The following is a description of a gene set: species: Homo sapiens Hypertrichosis is increased hair growth that is abnormal in quantity or location. Hypertrichosis Human Gene Set: HP_HYPERTRICHOSIS, and this is the list of marker genes: PPARG, KIFBP, GABRA3 (NCBI Gene Id 2556), SMARCC2, PCDHGC4, PIGN, KIAA0753, TAF6, CDKN2A, UROS, CHMP1A, PRR12, PACS1, FLII, NDST1 (NCBI Gene Id 3340), TRMT1 (tRNA methyltransferase 1), PGM2L1, GJA8, ARID1A, UQCC2, SNAI2 (NCBI Gene Id 6591), PLCB4, SMARCE1, SOX5, BLM, CASP2, TRMT10A, SMC1A, AFF4, DYM, FHL1, ZNF711, ZFX, HEATR3, TRAIP, PIK3CD, NAGLU, PTCH1, ADAMTS3, SMARCB1, FOS, KRT10, TMEM147, CCDC47, MASP1, TERT, ARID1B, SOX4, CDC42BPB, SCN4A, RAB34 (NCBI Gene Id 83871), COG7, CHRNA7, MITF, SLC4A10, NUDT2, COX5A, EHMT1, KIT, PUF60 (poly(U) binding splicing factor 60), MT-TQ, HNRNPU, MT-ND4, DPF2, ABCC9, PACS2, SMS, RNF125, BICRA, SMCHD1, CTSC, WAC, TALDO1, SMARCA4, ALK (NCBI Gene Id 238), HGSNAT, ZNF407, ATP6V1B2, MAPK8IP3, FBXO31, NANS, HECTD4, WARS1, MAN2B1, TMCO1, HSPA9, ZMYND11, ERLIN2, MT-ND5 (mitochondrially encoded NADH:ubiquinone oxidoreductase core subunit 5), IL6ST, FREM1, MT-TL1, KCNK4, AHDC1, DHX30, RAI1, RAC1, VPS33A, MAB21L1, ZBTB20, HMGA2, DDB1, MT-ND1, BSCL2, MBD5, EDNRB, CAV1, UBE2A, TMEM94, UFC1, CWF19L1, BGN, POLR3A, AFF3, KCNH1, PSMB8, BCAS3, SETD5, KDM4B, SGSH, MT-TF, CTCF (CCCTC-binding factor), TAF1, ANKRD11, ZEB2, GPC4, FBXO28, FGF3, SPTBN1, GLB1, SETBP1, UROD, RPS23, TRAPPC10, ARL3, FRA10AC1, UGDH, NFIX, STAG1, SRD5A3, KNSTRN, SOX10, GPR101, NECTIN1, PSMD12, TOE1, UGP2, CDKL5, SMARCD1, CLP1, CKAP2L, NSUN2, SLC32A1, ASXL2, SPOP, PRKG2, NOTCH2, PIGU, ASXL3, ZNF699, AMMECR1, CDH2, RAF1, AGPAT2, WNT4, MT-ND6, DEAF1, CDC42, MT-CO3, SMPD4, GNA14, GATA1, KCNN3, CERT1, INSR, TP53, DPAGT1, EBF3, CAVIN1, BPTF, PHIP, B3GLCT, SRCAP, PHF8, IGF1R, NKX6-2, MT-CO1, NIPBL, CTNNB1, HDAC8, ACTB, AFG2A, KDM6A, RAD21, CSNK2A1, TUBGCP2, NUS1, UBAP2L, TRIM8, SLC25A24, TASP1, TRAPPC9, FOSL2, CHD5, DOCK7, KDM1A, SUZ12, BRAF, XYLT1, CLCN3, MT-TW, KMT2D, HIVEP2, PSMC3, TAF4, SNX14, ASXL1, CUL4B, JARID2, FBXL4, GNS, ASH1L, FGFR1, ESAM, UBR7, BAP1, PAX3, GJA5, IL1RAPL1, MED27, NRAS, ZNF292, ABCA5, NMNAT1, USP9X, GPC3, TBCK (TBC1 domain containing kinase), IQSEC2, EIF4A2, MAPRE2, CHSY1, PPP1R15B, PRKAR1A, ZNRF3, MT-TS2, GNE, TWIST2, SLC29A3, SMARCA2, EP300, SOX11, BRD4, MT-CO2 (mitochondrially encoded cytochrome c oxidase II), MAP1B (microtubule associated protein 1B), MAPK1, CDON, TTI2, NEU1, SLC1A4, CDH11, LEMD3, RAB3GAP1, KIF26A, NDUFA12, GNB2, AIP, CNTNAP2, PPOX, ALG9, TBCD, KCNMA1, BMP2, LTBP3, HID1, KMT2A, KATNB1, WBP11, ARID2, SMC3, GJB4, EDN3, RUSC2, TLK2, SPEN, KLF13, CREBBP, ADAT3, KNL1 (kinetochore scaffold 1), RAB18, IDS, MT-TH, TRIO, OGT, MED13, ZIC2, EMC10, TFE3, VPS37A, ARX, CDK10